The following is a description of a gene set: Mouse Gene Set: GOBP_GROWTH_INVOLVED_IN_HEART_MORPHOGENESIS studied in species Mus musculus Developmental growth that contributes to the shaping of the heart., and this is the list of marker genes: S1pr1, Notch1, Sirt6, Mesp1, Ahr, Adprhl1